Given this list of marker genes POLRMT, TFB2M, MTERF1, TFAM (transcription factor A, mitochondrial), here is a description of the gene set: Reactome Pathway: Transcription from mitochondrial promoters part of: Gene expression (Transcription) Thirteen of the ~80 different proteins present in the respiratory chain of human mitochondria are encoded by the mitochondrial genome (mtDNA). The circular mtDNA, which is present in 1000 to 10000 copies in the human cell, also encodes for 2 ribosomal RNAs, and 22 transfer RNAs. The double-stranded mitochondrial genome lacks introns and the longer non-coding region contains the control elements for transcription and replication of mtDNA. The two mtDNA strands are referred to as the heavy (H-strand) and the light (L-strand) due to their differing G+T content. In human cells, each strand contains one single promoter for transcriptional initiation, the light-strand promoter (LSP) or the heavy-strand promoter (HSP). Transcription from the mitochondrial promoters produce polycistronic precursor RNA encompassing all the genetic information encoded in each of the specific strands. The primary transcripts are processed to produce the individual tRNA and mRNA molecules. There is likely a second initiation site for heavy strand transcription, which produces RNAs spanning the rDNA region. The resulting transcript including the genes for the two mitochondrial rRNAs and ends at the boundary between the 16 S rRNA and the tRNALeu(UUR) genes. The existence of such a separate transcription unit may explain why the steady-state levels of rRNAs are much higher than the steady state levels of mRNAs. species: Homo sapiens